Given this list of marker genes ITGB2, HLA-B, P4HA2, MEFV, PTPN22, HLA-DRB1, here is a description of the gene set: Increased concentration of fibrinogen in the blood. Human Gene Set: HP_HYPERFIBRINOGENEMIA species: Homo sapiens Hyperfibrinogenemia